Given this list of marker genes Errfi1, C3, Cdh1, Ctnnb1, Csmd1, Lhx1, Wnt7a, here is a description of the gene set: Mouse Gene Set: GOBP_OVIDUCT_DEVELOPMENT studied in species Mus musculus The reproductive developmental process whose specific outcome is the progression of an oviduct over time, from its formation to the mature structure. An oviduct is a tube through which an ova passes from the ovary to the uterus, or from the ovary to the outside of the organism.